Given this list of marker genes GSTK1, TRAF5, IVD, PRKCI, GPSM2, SCAMP1, JCHAIN, CMTM3, HDDC2, SERPINB6, MINPP1, RPA3, FASN, CCNJ, SEH1L, MITF, TIMP2, ANAPC13, LIN7C, MICOS13, FKBP1A, RTCA, GPX3, RBM3, GAB1, UQCR10, MAGOH, TMED5, COTL1, RPS10, ZFX, PSCA, DIS3, RILPL2, CXCL11, TSPAN5, GNG10, CAMK2D, CAMP, RYR1, CAPZA1 (capping actin protein of muscle Z-line subunit alpha 1), FGL2, TFEC, EEF1D, CACNG7, SLC25A4, NAB2, SLC38A5, NUSAP1, BIRC3, PPP1R14B, ACLY, DVL2, SLC4A7, STK39, SSBP4, MEF2C, ELP5, NAGK, MPC2, ACOT9, TOX4, EXOC4, HIPK3, NFKBIZ, HKDC1, ABCG2 (NCBI Gene Id 9429), NDUFB5 (NCBI Gene Id 96666), DEPDC1, ARHGAP6, ATP6V0A2, KLF7, ADAM23, AKR7A2, MMP12, TM6SF1, KCNN4, INSM1, PRAF2, UNC119, ATP5F1C, PGK1, GSTO1, CAMK2B (calcium/calmodulin dependent protein kinase II beta), NCKAP1L, UQCRC1, EIPR1, RPS16, DENND2D, ACTG2, NDUFA11, MBTD1, NSMF, UQCRFS1, UFM1, GRAMD4 (NCBI Gene Id 23151), NR1I3, S100A13, PSRC1, MTMR14, CCDC80, YBX1, GALNT1, CLEC5A, SND1, PLOD2, PIM1, MIOX, ABCB10, LSM12, PDCL2, ATP5F1D, MIP, PDIA6, CD70 (CD70 molecule), MFSD10, TRAM1, RIPOR1, SERTAD2 (SERTA domain containing 2), TIMM8A, ICOS, LARP7, ANKRD13A, SNAP29, SRP54, BRCA1, NSUN2, GLUD1, SLC30A6, MET, PRMT3, PRMT7, NLRP3, CALCRL, FOXK1, BIRC5, LPCAT1, PAPOLB, CHCHD10, SEM1 (NCBI Gene Id 7979), CDK1 (NCBI Gene Id 983), CDA (NCBI Gene Id 978), CCL2, COX6A1, EVI2B, IKZF4, CLEC7A (NCBI Gene Id 64581), HMGCR, PLGRKT, NKX2-8, IARS1, S100A1, RACGAP1, COPA, DDX54, RNASE4 (NCBI Gene Id 6038), DNAJC3, CRTAP, GPRC6A, ARL14EP, FMOD, ANXA2, GJB4, ACAD9, MRPL35, ME2, TFG, VEGFD, GATA3, ETFA, EXOSC10, DPH6, LSS, NDUFB10, RPL36, MRPL23, PTBP3, MFSD14A, TNFRSF1A, MRPL11, NUP160, SECTM1 (secreted and transmembrane 1), LYAR, SLC7A5, CHURC1, TNFRSF18, AIFM1, PLTP, TIMM23, MAD2L1, SPRYD7, CEP55, SLC1A5, PCCB, HBEGF, CTSE, RRP9, UBXN2A, NKX2-2, here is a description of the gene set: mouse primary BMDCs were stimulated with tlr ligands and gene expression changes were profiled on Affymetrix arrays from publication Amit I, Garber M, Chevrier N, Leite AP, Donner Y, Eisenhaure T, Guttman M, Grenier JK, Li W, Zuk O, Schubert LA, Birditt B, Shay T, Goren A, Zhang X, Smith Z, Deering R, McDonald RC, Cabili M, Bernstein BE, Rinn JL, Meissner A, Root DE, Hacohen N, Regev A (PMID 19729616) Human Gene Set: GSE17721_4H_VS_24H_POLYIC_BMDC_UP studied in species Homo sapiens Genes up-regulated in comparison of dendritic cells (DC) stimulated with poly(I:C) (TLR3 agonist) at 4 h versus those stimulated at 24 h.